Given this list of marker genes ENPP1, HLA-B, MLX, XYLT2, ABCC6, XYLT1, IL12B, RASA1, here is a description of the gene set: Human Gene Set: HP_ABNORMAL_PULSE studied in species Homo sapiens An anomaly of the rhythmic throbbing of an artery that reflects the widening of the artery as blood flows through it and is caused by successive contractions of the heart. Abnormal pulse